Given this list of marker genes Cln3, P2rx1, Cyp2r1, Gstp-ps, Lpcat4 (NCBI Gene Id 99010), Gprc6a, Hmgcll1, Hsd3b6, Ldlr, Pcyt1a, Ubr4, Gstm4, Pigp, Mlxipl, Paqr4, Pi4k2b, C3, ENSMUSG00000144291, Capn2, Med1, Insig2, Pik3c2a, Pik3c2g, Npy1r, Akt1, Ces1d, Chp1, Trib3, Abca8b, Avpr1a (arginine vasopressin receptor 1A), Ebp, Mppe1, Cds2, Acsf3, Stard4, H6pd, Mgll (NCBI Gene Id 57888), Fgf15, Fitm2, Fig4, Dgkq, Acsl4, Fdps, Npc1l1, Ceacam1, Gpaa1, Zfp750, Prkcd (NCBI Gene Id 52581), Gk, Hacd4, Smpd1, Cyp1a1, Akr1c18, Pecr, St6galnac4, B4galt3, Pigk, Ces1h, St8sia2, Pla2g10, Fgf1, Tnf, Hmgcs1, Adgrf5 (adhesion G protein-coupled receptor F5), Elovl1, Mid1ip1, Pip5k1a, Hsd17b11, Ugt8a, Dcaf5, Serinc1, Elovl5, Gsdmd (NCBI Gene Id 69146), Hsd17b3, Dgkd, Atg7, Pla2g6, Pex5, Rdh16f2, Abcd1, Fads2, Prf1, Srd5a1, Ces1f, Scd1 (NCBI Gene Id 20249), St3gal2 (NCBI Gene Id 20444), St6galnac1, Hmgcr, Agps, Srebf2, Acsm3, Acss1, Kat2b (K(lysine) acetyltransferase 2B), Cept1, Kdsr, Cers4, Prox1, Ptges, Rdh1, Ptges3, Agmo, Ccdc3, Ifng, Rdh10, Tmem135, Hnf4a, Erlin1, Dgat2l6, Acadvl, Dkkl1, Ggt5, Pcyt2, Nus1, Pip5k1c, Obp2a, Vac14, Acsbg2, Acsm1, Bmp2, Sf1, Mogat1, Pnliprp1, Plp1, Pgap1, Abcg4, Fgf7, Avp, Pck1, Srd5a2, Hsd17b4, Apoa2, Abcg1, Pex7, Ppara, Nr1d1, Agpat3, Nr1h2, Acbd3, Pigt, Dhcr24, St8sia5, Lpin1, Ggta1, Ctdnep1, 4930402F06Rik, Ndufab1, Hmgcl, Plin5, Mup2, Atm, Igf2, Hexb, Wdtc1, Gal3st2, Apoc2l, St3gal3, Htd2, Pla2g5, Gpam, St8sia4, Gpld1, Gnpat, Pla2g15, Sirt4, Agpat2, Klhl25, Erg28, Scd3, Chpt1 (choline phosphotransferase 1), Mlst8, Pigs, Aldh1a3, Dolk, Sphk2, Abhd5 (NCBI Gene Id 69842), Sirt2, Dagla, Lpin2, Faxdc2, Degs1, Alox15, Ptgis, Acox1, Elovl4, Cnep1r1, Crebl2, Bpnt1, Sgms2, Dpm1, Apoe, Pdgfb, Rpe65, Acot7, Sgms1, Cyp17a1, Rgn, Cers6, Acot8, Akr1c6, Cyp19a1, Lss, Ptgds, Aqp8, Cyp21a1, Cyp11a1, Lpin3, Bmp5, Pik3c2b, Cyp27a1, Pdk4, Vapa (vesicle-associated membrane protein, associated protein A), Zbtb20, Mogat2, Rdh9, Gpr146, Slc35c1, Mfsd2a, Ptges3-ps, Hsd11b1, Atp1a1, Malrd1, Hpgds, Chka, Ptprq, Gip, Pcx, Impa2, Pnpla1, Acat1, Lpgat1, Acss2, Asxl3, Pigq, Hsd17b8, Abhd8, Scap, Hsd17b7 (hydroxysteroid (17-beta) dehydrogenase 7), Dgat2, P2rx7, Agt, Akr1c14, Acsl3, Inhba, Mboat2, Plpp1, Gper1, Fa2h, Pgap3, Coq2, Cds1, Star, Erlin2, Ces1g, Nr3c1, Gh, Sc5d, Pigv, Pgap4, Prkag2, Hdhd5, Fitm1, Awat2, St3gal4, Rbp2 (NCBI Gene Id 19660), Lipa, Pigx, Abhd6, B4galt6, Mup3, Nr1h3, Acsbg3, Pik3r1, Pisd (phosphatidylserine decarboxylase), Por, Dgka, Tlcd3b, Bpnt2, Ppard, Ip6k1, Sik2, Pik3ca, Pigo, Crppa, Pibf1, Prpf19, Hacd3, Apoa4, Dhrs9, Plscr3, Sirt1, Ptgs2, Avil, Pdgfa, Akr1c20, Pdss2, Tafazzin, Armc5, Cyp51, Plscr1, Mboat7, Il1a, Cyp11b1, Rest, Mvd, Abhd2, Ang, Igf1r, Mif, Tmx1, Uvrag, Pign, Bmp6, Cyp39a1, Bmpr1b, Idi2l, Ces1a, Thnsl2, Asah1, Alox8, Pgs1, Creb1, Lpcat1, Ces1b, Cyp27b1, Sdr42e1, Sorbs1 (NCBI Gene Id 75688), Lcat, Nr5a2, Ormdl3, Abhd4, Smpd2, Fgfr4, Myo5a, Mup1, Cmtm2a (CKLF-like MARVEL transmembrane domain containing 2A), Dgki, Fut9, Sptlc1, Elovl6, Cd74, Cyp4f39, Akr1c21, Lhcgr, Agk, Alox12b, Inpp4b, Impa1, Dhrs11, Cyp24a1, Htr2c, Far2, Lpl, Rictor, Hacd2, Tm9sf2, Crh, Aldh8a1, Thrsp, Snai2, Acsl5, Serinc4, Apoa5, Sh3glb1 (SH3-domain GRB2-like B1 (endophilin)), Becn1, Pck2, B3gnt5, Anxa1, Plcg2, Lep, Bscl2, St6galnac3, Serinc5, Smg1, Lpcat2b, Ugcg, Paqr3, St3gal1, Hsd3b2, Mecr, Aldh1a1 (NCBI Gene Id 320092), A4galt, Mboat1, Prmt3, Dgke, Igfbp7 (insulin-like growth factor binding protein 7), Fads3, Idi1-ps1, Fads2b, Cyb5r2, Ppargc1a, Hsd3b4, Bglap2, Pik3c3, Acsbg1, Dctn6, Idi1, Tecrl, Sqle, Inppl1, Pigb, Trex1, Abcd2, Il1b, Hsd17b1, Fabp5, Pld2, Pik3r4, Ttc7, Serac1, Insig1, Hint2, Decr2, Gal3st3, Lpcat2, Pcyt1b, Acaa1b, Cyp7b1, Ch25h, Nr1h4, Ggps1, Itpkc, Ceacam2, Cacna1h, Dgkk, Gstp2, Hsd3b5, Prkab1, Abo, Aldh1a2, Ptdss2, Casp7, Qki, Dhrs7b, Prkab2, Inpp1, Abca2, Bglap, Brca1, Smpd3, Pigc, Flvcr1, Rdh19, Mtor, Pip4k2b, Pde8b, Gpat3, Cyp8b1, Pigz, Slc45a3, Peds1 (NCBI Gene Id 98887), Apoc2 (NCBI Gene Id 11813), Sod1, Pigg, Dgkb, Cers1, Dgkh, Pigl, Slc27a5, Sptssa, Gstm2, Smpd4, Acsm4, Pnliprp2, Pla2g1b, Wnt4, Pigf, Pgap2, Hmgcs2, Pbx1, Pnpla8, Egr1, 3110082I17Rik, Gba2, Sh3yl1, Lpcat3, Alox12, Gstm1, Far1, Tmem68, Fasn, Acer1, Scd2, Crls1, Pi4kb, Etnk1, Mlx (NCBI Gene Id 56875), Ttc7b, St6galnac5, Mup5, Tm7sf2, Edn1, Degs2, Mapk1 (NCBI Gene Id 98012), Tmem38b, Pik3cb, Dgat1, Pex2, Plaat3, Atg14, Elovl3, Ang6, Igf1, Abca3, Hsd3b7, Pnlip (NCBI Gene Id 69060), Mapk9, Tcf7l2, Pigh, Prkag3, Cyb5r3 (cytochrome b5 reductase 3), Tbxas1, Prkaa2, Inpp5e, Casp1, Pik3cd, Aloxe3, Lipc, Sphk1, Tmem150a, Abca8a, Acer3, Ip6k2, Pla2g3, Hsd17b12, Hycc1, Dhcr7, Cthrc1, Enpp7, Hnf1a, Pi4ka, Ajuba, Abhd1, Dhdds, Pip4k2a, Hsd17b2, Dbi, Ccn1, Smpd5, Adora2b, Pnpla3, Sccpdh, Pyurf, Sptssb, Elovl2, St8sia3, Sec14l2, Oxsm, Cers3, Pi4k2a, Pam, Fdxr, Ip6k3, Hacd1, 6430550D23Rik, Ogt, Nsdhl, Srd5a3, Efr3b, Prkaa1, Ang4 (NCBI Gene Id 328486), Eif6 (eukaryotic translation initiation factor 6), B4galnt2, Cwh43, Cers5, Hsd3b1, Chkb, Gstm6, Pip5kl1, Lbr, Gstm3, Daglb, St3gal6, B3galt2, Apoc3, Dpm3, Acaca, Gstp1, Glt6d1, Apoa1, Asah2, Srebf1, Fshb, Scarb1, Degs1l, Msmo1, Samd8, Ang5, Acadl, Acsm5, Pla2g2a, B4galt4, Fabp3, Apob, Scd4, Gm6993 (predicted gene 6993), Gzmb, Htr2a, Snai1, Pip4k2c, Cftr, Ces1c, Nr0b1, Slc27a1, Mup11, Gba1, Pla2g4f, Pemt, Clcn2, Agpat1, Sptlc2, Gbgt1, Dab2, Pigw, Rab38 (RAB38, member RAS oncogene family), Htr2b, Plce1, Cyp11b2, Piga, Lclat1, Rdh16, Acly, Acsl1, Prkaca, Cdipt, Serpina12, Dgkg, Cerkl, Cyb5r1, Gm2044, Gstp3, Pigm, Acsm2 (NCBI Gene Id 233799), Erbb4, Mvk, Abcd3, Apoc1, Hsd3b9, Fdft1, Agpat5, Tecr, Pla2g4c, Itpkb, B4galt5, Prkag1, Bckdk, Pmvk, 4930568D16Rik, Dhh, Fut4, Fads6, Inpp4a, Stard3, Gpat2, Ang2, Hsd3b3, Itpka, Slc30a5, Mbtps2, Nfkb1, Ltc4s, Ormdl1, Gcdh, Sco1, Gnai1, Acsl6, Selenoi, Sirt3, Ptgs1, Ptpmt1, Sptlc3, B4galnt1, Hrh1, Scp2, Ormdl2, B3galt1, Ces1e, Elovl7, Prxl2b, Dgkz, Rptor, Idh1, Osbp, Pigu, Cyp7a1, Cga, Mlycd, Ptdss1, Hycc2, Lias, Mup4 (major urinary protein 4), Tamm41, A3galt2, Agpat4 (1-acylglycerol-3-phosphate O-acyltransferase 4), Hsd3b8, Olah, Mcat, Acacb (NCBI Gene Id 97267), St6galnac6, Fdx1, Gstm7, Gal3st1, St8sia6, Ehhadh, B3galt4, Kat5, Cers2, Fads1, Idi2, Alox5, Abhd3, Isyna1, Etnk2, Gpat4, Dpm2, Acer2, Tspo, Lipg, G6pdx, Pnpla2, G6pd2, Ptges2, Gfi1, Rbp1, Pla2g4a, Acaa1a, Pip5k1b, Cbr4, Ddx20, Pigyl, Sik1, Pdss1, Hsd17b13, Pik3cg, Dkk3, Prkg1, Edn2, Pld1, Ggcx, here is a description of the gene set: species: Mus musculus The chemical reactions and pathways resulting in the formation of lipids, compounds soluble in an organic solvent but not, or sparingly, in an aqueous solvent. Mouse Gene Set: GOBP_LIPID_BIOSYNTHETIC_PROCESS